Given this list of marker genes SLC15A4, SLC15A3, SLC7A11, SLC15A1, SLC15A2, here is a description of the gene set: The directed movement of an oligopeptide from outside of a cell, across the plasma membrane and into the cytosol. Human Gene Set: GOBP_OLIGOPEPTIDE_IMPORT_ACROSS_PLASMA_MEMBRANE species: Homo sapiens